Given this list of marker genes BHMT, CHDH, MTAP, APIP (NCBI Gene Id 51074), AHCY, MAT2B, MSRB2, MAT1A, SMS, TAT, MRI1, AMD1, ODC1, MSRB3, MAT2A, MSRA, ENOPH1, TXN, SRM, ADI1, IL4I1, MTR, here is a description of the gene set: species: Homo sapiens Human Gene Set: WP_METHIONINE_DE_NOVO_AND_SALVAGE_PATHWAY Methionine de novo and salvage pathway